The following is a description of a gene set: Genes up-regulated in peripheral blood mononuclear cell stimulated vs unstimulated in adults (37-48) after exposure to HIV-LIPO-5, time point 14W. Comment: top functional network of up-regulated genes studied in species Homo sapiens from publication Richert L, Hue S, Hocini H, Raimbault M, Lacabaratz C, Surenaud M, Wiedemann A, Tisserand P, Durier C, Salmon D, Lelièvre JD, Chêne G, Thiébaut R, Lévy Y, ANRS Vaccine Network/Vaccine Research Institute (PMID 23759749) Human Gene Set: RICHERT_PBMC_HIV_LIPO_5_AGE_37_48YO_STIMULATED_VS_UNSTIMULATED_14W_TOP_FUNCTIONAL_NETWORK_UP OBJECTIVE: To dissect the biological mechanisms involved in the cellular responses to a candidate vaccine containing 5 HIV peptides coupled to a palmytoil tail (HIV-LIPO-5) in healthy volunteers, by using extensive immunogenicity assessments with different stimulation durations. DESIGN: Immunogenicity substudy of a randomized phase II prophylactic HIV vaccine trial (ANRS VAC 18). METHODS: HIV-LIPO-5 or placebo was administered at W0, W4, W12 and W24. Peripheral blood mononuclear cells from a subset of participants at W0 and W14 were stimulated with HIV-LIPO-5, Gag peptides contained in the vaccine and control peptides. ELISpot, lymphoproliferation, intracellular cytokine staining (ICS), cytokine multiplex and transcriptomic analyses were performed. Different time points and stimulation conditions were compared, controlling for test multiplicity. RESULTS: Cultured ELISpot and lymphoproliferation responses were detected at W14. Ex-vivo ICS showed mainly interleukin (IL)-2-producing cells. Secretion of interferon (IFN)-gamma, tumour necrosis factor (TNF)-alpha, IL-5 and IL-13 increased significantly after culture and Gag stimulation at W14 compared to W0. Metallothionein genes were consistently overexpressed after HIV-LIPO-5 stimulation at W0 and W14. At W14, significant probes increased substantially, including IFN-gamma, CXCL9, IL2RA, TNFAIP6, CCL3L1 and IL-6. Canonical pathway analyses indicated a role of interferon signalling genes in response to HIV-LIPO-5. CONCLUSION: HIV-LIPO-5 vaccination elicited Th1 and Th2 memory precursor responses and a consistent modulation in gene expression. The response profile before vaccination suggests an adjuvant effect of the lipid tail of HIV-LIPO-5. Our combined immunogenicity analyses allowed to identify a specific signature profile of HIV-LIPO-5 and indicate that HIV-LIPO-5 could be further developed as a prime in heterologous prime-boost strategies., and this is the list of marker genes: EBI3, IFNB1, SOCS1, IFNG, IL15RA, TLR10, PSMB9, TAP2, CD69, CXCL9, STAT1, UBD, UHMK1, CCL1, IL24, GBP1, TFPI2, TNFRSF4, CXCL6, SOCS2, TAP1, TNFRSF18, IL36G, RIPK2, IDO1, IL1A (NCBI Gene Id 3552)